Given this list of marker genes Trappc9, Sec16a, Preb, Trappc2, Ap3s2, Ap3m2, Trappc13, Trappc3, Sar1a, Mapk15, Arfgap3 (ADP-ribosylation factor GTPase activating protein 3), Trappc5, Ap3b2, Arfgap2, Trappc10, Trappc6b, Ap3s1, Trappc6a, Trappc2l, Gbf1, Trappc4, Trappc1, Pef1, Tmed9 (NCBI Gene Id 67511), Pdcd6, Ap3d1, Trappc11, Sar1b, Cul3, Klhl12, Trappc12, here is a description of the gene set: A protein coat is added to the vesicle to form the proper shape of the vesicle and to target the vesicle for transport to its destination. Mouse Gene Set: GOBP_VESICLE_COATING species: Mus musculus